Given this list of marker genes SMAD3, SMAD4, SMAD6, TGFB1I1, TGFBR1, SMAD7, SMAD1, SMAD9, ACVR1B, SMAD5, SMURF1, CTNNB1, AXIN1 (NCBI Gene Id 8312), SMAD2, AXIN2, FKBP1A, here is a description of the gene set: species: Homo sapiens Binding to an inhibitory SMAD signaling protein. Human Gene Set: GOMF_I_SMAD_BINDING